The following is a description of a gene set: The process in which the anatomical structures of branches are generated and organized. A branch is a division or offshoot from a main stem. Examples in animals would include blood vessels, nerves, lymphatics and other endothelial or epithelial tubes. Mouse Gene Set: GOBP_MORPHOGENESIS_OF_A_BRANCHING_STRUCTURE studied in species Mus musculus, and this is the list of marker genes: Nfatc3, Ahr, Gli3, Ctsh (NCBI Gene Id 13036), Col13a1, Spint2, Hnf1b, Ar, Cav3, Sall1, Hoxa5, Il10, Shox2, Eng, Trp63, Sfrp2, Wnt2, Cd44 (CD44 antigen), Spry2, Tmem67, Ihh, Lgr4, Esr1, Ptch1, Tbx3, Med1, Fgf13, Rtn4, Ctnnd2, Pdgfa, Grem1, Pax8, Ntn4, Nrp1, Vdr, Gpc3, Prdm1, Lrp6, Smo, Gna13, Pxn (paxillin), Foxa1, Myc, Edn1, Pml, Dag1, Cxcr4 (NCBI Gene Id 12767), Il1b, Sox9, Wnt2b, Notch4, Bcl11a, Cxcl12, Flt1, Fgf10, Etv5, Hoxd11, Pgr, Sox10, Fgfr1, Pak1, Foxa2, Tbx1, Tacstd2, Setd2, Greb1l, Lrrk2, Ilk, Ermn, Smad4, Pkd1, Dlx2, Socs3, Yap1, Hhip, Stk4, Drd2, Rere, Fgf7, Hoxa13, Casr, Csmd1, Cripto, Hs3st3a1, Wt1, Wnt4, Pdgfra, Sema3c, Plxna1, Ctnnbip1, Ext1, Sulf1, Srf, Tmem59l, Lhx1, Hoxb13, Pkd2, Btbd7, Clic4, Gli2, Dlg1, Pax2, Dchs1, Abl1, Fgf1, Sirt6, Tgfb1, Fkbpl, Nkx3-1, Tbx20, Sox8, Vangl2, Six1, Egf, Rxra, Agtr1b, Hmga2, Sox2, Tbx2 (T-box 2), Grb2, Slit2, Mgp, Fat4, Rdh10, Fgf2, Map3k13, Ddr1, Angpt1, Foxf1, Rspo2, Bmp7 (NCBI Gene Id 12162), Prox1, Ctsl, Pbx1, Csf1, Mks1, Slc12a2, Hs3st3b1, Notch1, Esrp1, Agtr1a, Gdf2, Dicer1, Epha7, Phb2, Gcm1, Fem1b, Epha2, Gdnf, Tcf21, Wnt5a, Tmtc3, Tgfbr2, Spint1, Dll4, Kras, Wnt1, Ccl11, Col4a1, Eya1, Cpe, Igf1, Celsr1, Ctnnb1, Wnt6, Cdh1, Sema3e, Six4, Tmed2, Gdf7, Vegfa, Pitx2, Mmp14, Nfatc1, Lama5, Tgm2, Areg, Lrp5, Ctsd, Hgf, Bmp2, Adamts16, Ppp1ca, Tek, Kdm5b, Nfatc4, Acvr1, Npnt, Pdgfb, Fgf8, Tie1, Mecp2, Grhl2, Tfap2c, Tnf, Nog, Rasip1, Nrarp, Ctsz, Timeless, Ednra, Gbx2, Bcl2, Bmp4, Sfrp1, Hhex, Lef1, Ncoa3, Shh (NCBI Gene Id 20423), Tnc, Esrp2, Spry1, Kdr, Rbm15, Wnt9b, Sema3a, Dspp, Met, Mdk, Sema5a, Etv4, Pgf, Foxd1, Msx2, Cited1, Plxnd1, Frs2, Maged1, Src, Hoxb7, Mycn (v-myc avian myelocytomatosis viral related oncogene, neuroblastoma derived), Cited2, Llgl2, Il6 (interleukin 6), Hoxa11, Nkx2-1, Agtr2, Adm, Ppp3r1, Pkhd1, Fgfr2, Pspn, Hnrnpk (heterogeneous nuclear ribonucleoprotein K), Lama1, Fzd5, St14, Rspo3, Agt, Hoxd13, Gzf1, Foxc2, Btrc, Dlg5, Six2, Snai2